The following is a description of a gene set: species: Mus musculus Any process that modulates the frequency, rate or extent of Wnt signaling pathway, planar cell polarity pathway. Mouse Gene Set: GOBP_REGULATION_OF_WNT_SIGNALING_PATHWAY_PLANAR_CELL_POLARITY_PATHWAY, and this is the list of marker genes: Abl1, Nphp3, Gpc3, Mks1, Mllt3, Plekha4, Dact1, Spef1, Nkd1, Dab2, Abl2, Znrf3, Ankrd6